The following is a description of a gene set: studied in species Homo sapiens Genes up-regulated in comparison of memory CD4 T cells from young donors treated with TSST at 16 h versus those from old donors treated with TSST at 16 h. Human Gene Set: GSE36476_YOUNG_VS_OLD_DONOR_MEMORY_CD4_TCELL_16H_TSST_ACT_UP from publication Yu M, Li G, Lee WW, Yuan M, Cui D, Weyand CM, Goronzy JJ (PMID 22434910) With increasing age, the ability of the immune system to protect against recurring infections or to control chronic infections erodes. The objective of the current study was to identify gene expression signatures in elderly CD4 T cell responses, and this is the list of marker genes: DST, DDB1, EXOG, ZDHHC14, POPDC2 (NCBI Gene Id 64091), TFDP3, DHODH, ARHGEF15, ATP6V0B, KPTN, ASB13, FAM149A, PMM2, TAPT1, OTUD7B, TEX2, PMVK, LINC00939, FOCAD, DMD, ANKRD28, HARS1, MYO16, NOL4, PDK4, FDFT1, ZIC3, ZNF214, CTPS1, ELP4, NEO1, CISD1, KRT33A, PUF60, CCDC86, MAP4K3, CXCL1, KCNS1, IGF2BP3, TTC23, PPP2R2B, ELOB, CYP4F3, NREP, FPR2, ME2, NAT10, ALLC, CYP11A1, RAB6B, ERAP2, ACKR2, GNAO1, STK24, MOGS, CCL25 (C-C motif chemokine ligand 25), MRM3, SMAD5, PTCH2, HBE1, CLN6, PSMB6, ELP5, FBLN1, DHCR7, TRIL, TAP1, DNAI7, MFSD5, DRD5, SLC12A1 (NCBI Gene Id 6557), SPSB1, HSPA14, ANK1, STAMBPL1, PTTG3P, NDN, PPT2, PTPN21, DHRS7B, EXOSC4, CACNA1H, SNX27, MICA, SLC12A5, RRP1B, C3AR1, RHOBTB3, KLHL41, ARPC5L, TGFB3, AFAP1, YIF1A, MYL1, MAP3K7CL, BMX, RFPL3S, HAS1, OR2C1, OLFML2A, PDLIM5, PRELID3A, CAMSAP1, ELOVL4, KCNQ3, CLCA1, PSMB2, BRINP1, MYH8 (myosin heavy chain 8), TMX2, CCDC102B, WARS1, HS3ST1, GLT8D2, SRPRB, SLC25A11, DUOX1, BCL2L13, WNT8B, TUBA8, NOP14, HTR3A, TRIM46, FXYD7, POLQ, FGF17, KLHL29, ATP10B (NCBI Gene Id 80225), AMPH, CIAO1, CIDEB, DNAI2, GTF3A, PRR34, PRUNE1, IL22RA1, STX4, SCGB1A1 (secretoglobin family 1A member 1), LIPC, PLEKHH3, ATP1A2, TIMM22, CDK10, GSTT2, CCT2, MAP3K20, ZNF682, C2orf49, WDR70, CHMP7, PLPPR4, AUTS2, GFRA1, DCLRE1A, ABHD10 (NCBI Gene Id 55347), SSX1, SLC13A1, PDE1A, AGPAT5, ADAMTS9, POLG, CDK20, METTL13, PCDHB6, DNMBP, BLMH, GPR31, MRM1, APOB, PENK, SERPINB4, SLC30A10, LUZP4, SERPINB10, CDH19, SP1, GYPA, AFF4, HESX1, FAM110B, CYP2B6, HES2, MSTN, CD151, CA11, RPL8, UQCRFS1, SLC43A3, SMTN, KIR3DX1 (NCBI Gene Id 90011), PRB3, ADH7, MCMBP, ABCA8, CYP4A11, KCNJ1